The following is a description of a gene set: Mouse Gene Set: TEAD2_TARGET_GENES Genes containing one or more binding sites for (Tead2) in their promoter regions (TSS -1000,+100 bp) as identified by GTRD version 20.06 ChIP-seq harmonization. studied in species Mus musculus from publication Yevshin I, Sharipov R, Kolmykov S, Kondrakhin Y, Kolpakov F (PMID 30445619), and this is the list of marker genes: 4930563E22Rik, Coro2a, Qrich2, Zfp276 (NCBI Gene Id 57247), Gm32950, Gm11873, Mir1967, Rpap2, Wsb2, Gm22020, Mlxipl, Gm17929, Gm15417, Ptpa, Gm24299, Zbtb38, Mir7689, Ap3m1, Ap1g1, Prkx, Cyfip1, Ywhag, Ankrd10, Mctp1, Ndufs2, Dnah7b, Nxpe2, Nfat5, Gm15545, Ubap2l, Gm24432, Gm23223, Ift172, Gm3363, Rbms3, Nfkbia, Ccl17, Gm34068, Gm24401, Pla2g10os, Adrm1, Gm13355, Fgf1, Pogz, Ins2, Map4k1, Mad2l1 (MAD2 mitotic arrest deficient-like 1), Chd3, Actl6a, Snord12, Cep89, Mri1, Yipf3, Greb1, Asap1, Dapk3, Fpgs, Flad1, Ttc23, Timm17b, 9030622O22Rik, Lrrc28 (NCBI Gene Id 70388), Abca17, Rab18, Bcl2l10, Rad18, Grm3, Glmn, Ogn, Ets1, Tcf4, Rapgef2, A630072M18Rik, Fam236d, Ldha (NCBI Gene Id 16828), Gm8609, Gm22866, Rreb1, Mmp10, Acmsd, 4930510E17Rik, Adgrl2, Angptl3 (angiopoietin-like 3), Vmn1r43, Vcp, Birc3, Gvin-ps7, Hs6st1, Gm10134 (NCBI Gene Id 100038637), Prim1 (NCBI Gene Id 19075), Il18, 2210417A02Rik (RIKEN cDNA 2210417A02 gene), Gckr, Zfp580, S100a2, Sh3bp5, Snord42b (small nucleolar RNA, C/D box 42B), Zswim3, Ngdn, Nsun2, Dab2ip, Trim23, Zkscan5, Polr2a, Adam4, Rasgrp2 (NCBI Gene Id 386467), Ppat, Kdm3a, Tanc1, Csn2, Rbfox2, Irf6, Gm2147, Gm24461, Akirin2, 5031434O11Rik, Ifitm7, Gm25791, Map3k14, Gde1, Cntnap5a (NCBI Gene Id 636808), Gm5510, Gm11638, Rnf6, Or5ar1, Mir7238, Cyp2w1, Gm15722, 4930509J09Rik, Lnx1, Mynn, Gm17501, Rad23a, Gm7052, 2310009B15Rik, Uhrf2, Gm12496, Gm10253, Sorcs2, Golgb1, Gm28269, Gm10286, Gm8501, Srd5a3, Antxr2, 1700125G22Rik, Spryd4, Vps53, Wwp2, Mir22, Ubqln2, Tmco4, Gm5870, Ampd3, Snapc4, Dusp11, Gm17521, Nsa2, Ftsj3, 2810407A14Rik, Myo10, Mir7018, Zic5, Creld1, Rsrp1, Mgat4d, Cdc7, Sp3, Gm23615, Ndor1, Cdc42bpa, Ctnnd1, Lrp8, Yars2, Rps26-ps1, Tsc22d4, Cdk6, A230001M10Rik, Sox4, Klc1, Hdac7, Szt2, Plaa, Rpl22l1, Psmc5, Rpl36-ps3, Vmn1r170, Parg, St18, Neb, Opn3, Rnf181, Tanc2, Tifab, Klk15 (kallikrein related-peptidase 15), Srrm2, Gm13333, Bex3, 4930425K10Rik, Nxt1, Gm25039, Gm9869, Rbm47, Gm12628, Ifrd1, Foxp1, Arrdc1, Msh2, Gm22358, Efcab6, Ifit1bl1, Gm5656, Trpc3, Ppp2r3c, Gm18018, Aifm1, Zfp46, Gm5181, Rmi2, Gm17797, Otud4, Pccb, Rnf126, Aknad1, Ipmk, Gm14784 (predicted gene 14784), Dusp3, Slit2, Gm13445, Marchf10, Timm10, Cdk12, Fbxw17 (NCBI Gene Id 97893), Adal, Gcfc2, Nelfcd, Adcy1, Morrbid, Mepce, Eif4g2, Stip1, 4933427I22Rik, Htra1, Gm22798, Gm5963, Ivns1abp, Sbds, Gm9060, Polr1c, Gm14107, Klhl1, Cib4, 9130230L23Rik, Gpn3, Gm24412, Mapk10, Fli1, Spred2, Chordc1, Slmap (sarcolemma associated protein), AU015836 (NCBI Gene Id 385493), Nsd3, Ptx4, Klc2, Cyp2c29, Tcp1-ps1, Lce1f (NCBI Gene Id 67828), Strn3, Gm24259, Ankhd1, Oxnad1, Hars2, Tesl2, Brme1, Scarb2, 1700019G24Rik, Gm20753, Oc90, Pard6a, Ercc4, Schip1, Gm16425, Abca2, Camsap2, Pds5a, Lrtm2, Clec2j, Pelo, Ccdc12 (NCBI Gene Id 97506), Pqbp1, Rxfp2, Fosl2, Iqca1, Spns2, Disp3, Pygm, Or55b3, Trappc3, Dmxl1, Or9i16, Fam8a1, Gm14115, Oga, Or2t6, Srd5a1, Cops6, Pag1, Comtd1, Tfeb, Kif24, Gtsf1, Zfp444, Ppp1r15b, Ccdc63, Or7h8, BC046401, Sp110-ps2, Eif2ak4, Mrpl32, Fzd3, Gm24677, Ywhae, Gm5239, Tmod1, Hnrnpl, Timm44, Gm40289, Cubn, Art2a, Myot, 2310010J17Rik, Lmo7, Ankrd24, Ccr6, Orm1, Grik2, Rtn4, Atp13a4, Cox18, 1700028N14Rik, Myo1h, Hinfp, Stat3, Gm4613, Zkscan3, Rprd1a, Gm5385, Mir3077, Ankrd54, Spdye4a, Txnrd1, Ndufs3, Magec2, Dmap1, Rpl23a, Gm9439, Mir5618, Aplp2, Cep20, Bcas2, Satb2, Acot8, Dot1l, Prorp, Ccn1, Mir7-2, Mtf2, Or5b12, Olfm2, Ash1l, Gcnt2, Or8d1b, Gm14147, Klf1, Arpc2, Gm9530, Sp1, 4930481B07Rik, Niban2, Mapk7, 2310022A10Rik, Satb1, Cnih3, Rogdi (NCBI Gene Id 98005), Wbp2, Lrrc15, Rnf222, Pros1, Creb3l2, Ly6g, Drc3, Gbp11, Rps6kb1, Orc1, Rin1, Nav3, Slc35a2, Slc4a1, Pdzd9, Zfp385b, Mcm5, Myl6, Naglu, Or52d13, Spata6l, Ap2a1, Picalm, Ccr9, Mir3968, Rbm22, U2af2, Gm5298, Gm28552, Slc36a1, Cfap97d1, Vwa5a, Pld3, Ppp1r2-ps3, Akirin1, Sap18, Trbv24, Gm12796, Ptk2b (PTK2 protein tyrosine kinase 2 beta), Iftap, Or5m10b, Kcnab2, Phlpp1, Pop7, Rps10-ps2, Parp3, Hsd11b1, Gm14688, Gm31752, Duxf1, Ndel1, Dop1a, B4galt3, Nmd3, Ss18l2, Ssbp2, Artn, Tmcc1, Vgll4, Gm23093, Cyth3, Pwwp2a, Kat6b, Galr2, Runx2os2, Zc3h7a, Hnrnph1, Nlk, Gm22840, Gm26441, Pik3r1, Kif4, Prkar2a, Ccdc93, Sergef, Usp45, Atosb, Ubash3b, Ehmt1, Zfp169, Gm11735, Fadd, Amotl2, Gm24292, Dph3b-ps, Rps18-ps3, Zfyve27, Zcwpw1, Ppa1, Atp6v0a2, Etfb, Eif4a2, Mtch2, Ect2, Cd109, Gm24437, Celf3, Lrch4, Rorc, Castor1 (cytosolic arginine sensor for mTORC1 subunit 1), Nuak1, Gm9239, Reg1, Ndufa12, Gys1, Siah1b, Bahcc1, Pde9a, Ptgs1, Gm23201, Pfdn1, B3galnt2, Gm14707, Gm12128, Ajuba, Inpp5a, Gm21461, Gm13332, Ppp6c, Tubd1, Rbp2, Gpr135, Or8h10, Hoxa1, Il23a (interleukin 23, alpha subunit p19, NCBI Gene Id 83430), Rs1, Ift122, Palb2, Osbpl9, Jph4, Pcdhga6, Gm18181, Fxr2, Sertad2, Bcas1, Adcy7, Acd, Sertm2, Gale, Acot4, Ehbp1, Klc3, Gtpbp10, Zp1, Pon3, Prb1c (proline-rich protein BstNI subfamily 1C), Pml, Spem1, Opa1, Gm12125, Nanos2, Dlg1, Galnt6, Kcnab3, Pbx3, Gm6602, Gm14137, 3300005D01Rik, Lhx2, Dlgap3, Smyd3, Gm15128, Gm5125, Gm25095, Ark2n, Cybb, Spopl, Hdac6, G3bp2, Ctps1 (NCBI Gene Id 51797), Tmem165, Trappc13, Btbd10, Wrap53, Cdk4, Sf3b6, Atp11a, Gck, Csn1s2b, Mtdh, Fam221a, Rpusd3, Hcfc1, Ndufaf6, Kcnq2, Irf8, Tex29, Med31, Gm23674, Plekhg2, Arpp21, Capn10, Ift27, Dcaf12, Gm12136, Sec61b, Map7, Kifap3, Gpr85, Gm12244, Treml4, Gm11950, Cc2d1a, Cpne4, Nup107, Fbxo48, Zfp128, Slc16a7, Asxl3, Gm26420, Ing4, Pus7l, Trmt6, Ntn1 (NCBI Gene Id 276903), Ccdc102a, Gm24751, Kif12, Gm26143, Trip12, Fhdc1, Ccn2, Gfm2, Gm16712, Gm12094, Dnm1, Scn5a, Mill2, Atp1a2, Gm18552, Fam107b, Gm15881, Fhit, 4930579O11Rik, Arhgap12, Faap24, Gm24988, Mcoln1, Hsd17b14, Sema3d, Hnrnpc, Zbtb7b, Prrc2c, S100a3, 4933434E20Rik, Cdip1, Runx1t1, Osbp, Parl, Nbea, Slc25a25, Gm18916, Dctn5, Mpzl3, AAdacl4fm3, Krtap14, Rhobtb3, Abca7, Zfp287, Cwc27, Acox2, D730045B01Rik, Tlk2, Dock11, Or12e9, Ankrd1 (NCBI Gene Id 12907), Cop1, Lrpprc, Zfp638 (NCBI Gene Id 18139), Rab10, Gm25558, Gm11691, Vps37a, Il1rap, Vmn1r237, Arf2, Gm15071, Pex7, Gm11700, Aebp2, Igsf9, Rfxank, Stk40, Gab1, Rrp9, Ptprf, Musk, Tnfaip6, Hdac4, Gm13387, Spag9, Trpc7, Tas2r137, Gm19705, Gm36535, Zc3hc1, Slc25a23, A830008E24Rik, Alg2, Pdxdc1, 1810034E14Rik, 4933438B17Rik, Gm7008, Or6b1, Adap1, Urb2, Plekha7, Clu, Eif3k, Pls3, Gm14746, Acin1, Psma2, Tom1l2, 1700120C14Rik (RIKEN cDNA 1700120C14 gene), Gm13024, Mir1938, Kpna2, G3bp1, Slc30a7, Rdm1, Borcs8, Stfa3, 5730480H06Rik, Gpr180, Gm20257, Dlg3, Bax, Loxhd1, Phyhd1, Bmpr1b, Ctla2b, Erbb3, Nek10, Angptl8, Fam3b, Zfp687, 0610012D04Rik, Shprh, Slc23a1, Gpr174, Nxf7, Zbtb24, Gm2670, Col11a1, Nr4a3 (nuclear receptor subfamily 4, group A, member 3), Thoc2, Crb3, Gm25204, Gm28926, Syt12, Ormdl1, Pagr1a, Lypla1 (lysophospholipase 1), Pvr